The following is a description of a gene set: Mouse Gene Set: GOBP_MESODERM_MORPHOGENESIS species: Mus musculus The process in which the anatomical structures of the mesoderm are generated and organized., and this is the list of marker genes: Nf2, Sfrp2, Ecsit, Tcf7l1, Ahdc1, Ext1, Srf, Gpi1, Foxf1, Wnt11, Gja1, Nodal, Acvr1, Wnt3a (NCBI Gene Id 22416), Snai1, Pofut2, Twsg1, Pax2, Msgn1, Itgb1, Smad3, Hoxa11, Foxc2, Smad2, Mesp2, Crb2, Mesp1, Kdm6b, Axin1, Hmga2, Setd2, Etv2, Smad1, Chrd, Wnt5a, Itga8, Prkaca, Tbx3, Lef1, Fgfr1 (NCBI Gene Id 14182), Wls, Scx, Ext2, Six2, Tbx19, Tbx6, Epha2, Txnrd1, Tlx2, Dkk1, Bmp7, Prkar1a, Bmpr1a, Htt, Bmp4, Macf1, Kdm6a, Foxc1, Inhba (inhibin beta-A), Itgb4, Apela, Itgb3, Hand1, Eomes, Nog, Wnt3, Bmpr2, Itga2 (integrin alpha 2), Epb41l5, Nanog, Exoc4, Pou5f1, Itga3, T, Taf10, Armc5, Hnf1a (HNF1 homeobox A), Eya1, Nckap1 (NCBI Gene Id 96983), Tal1, Nr4a3